Given this list of marker genes H2-Q6, H2-Q4, Tapbp, H2-Q7 (NCBI Gene Id 15018), H2-Q1, H2-Q2, H2-D1, Tapbpl, H2-K1, H2-Q10, here is a description of the gene set: Mouse Gene Set: GOMF_TAP_COMPLEX_BINDING Binding to a TAP complex. studied in species Mus musculus